The following is a description of a gene set: Human Gene Set: MCBRYAN_TERMINAL_END_BUD_UP Expression microarray analysis identified over genes regulated during puberty in the mouse mammary gland. Most prominent were genes whose expression increased in parallel with pubertal development and remained high thereafter. Members of the Wnt, transforming growth factor-beta and oestrogen-signalling pathways were significantly overrepresented. Comparison to expression data from CITED1 knockout mice identified a subset of oestrogen-responsive genes displaying altered expression in the absence of CITED1. Included in this subset are stanniocalcin2 (Stc2) and amphiregulin (Areg). Chromatin immunoprecipitation revealed that ERalpha binds to oestrogen response elements in both the Stc2 and Areg genes in the mammary gland during puberty. Additionally, CITED1 and ERalpha localize to the same epithelial cells of the pubertal mammary gland, supporting a role for interaction of these two proteins during normal development. In a human breast cancer data set, expression of Stc2, Areg and CITED1 parallel that of ERalpha. Similar to ERalpha, CITED1 expression correlates with good outcome in breast cancer, implying that potential maintenance of the ERalpha-CITED1 co-regulated signalling pathway in breast tumours can indicate good prognosis. from publication McBryan J, Howlin J, Kenny PA, Shioda T, Martin F (PMID 17486082) The 'TEB profile genes': up-regulated during pubertal mammary gland development specifically in the TEB (terminal end bud) structures. studied in species Mus musculus, and this is the list of marker genes: SFRP1, MYH11 (myosin heavy chain 11), IGFBP2, TNFRSF12A, RNF149, LY6D, TNS1, SDC1, EGR2, EHF, CDK1, CNN1